Given this list of marker genes ASMT, AANAT, TPH2, DDC, TPH1, ALDH2, here is a description of the gene set: studied in species Homo sapiens The chemical reactions and pathways resulting in the formation of compounds that contain an indole (2,3-benzopyrrole) skeleton. Human Gene Set: GOBP_INDOLE_CONTAINING_COMPOUND_BIOSYNTHETIC_PROCESS